Given this list of marker genes RIF1, RABGGTB, PAN3, TBXAS1, FAHD1, URB1, HCFC2, RMI1, NSD2, PHF3, RBM10, GCNT1, RREB1, H2BC21, TPRKB, FTSJ3, PPCDC, PDS5A, LRP6, OSBPL2, NARF, C2CD2, ATP10D, FUT4, PABPN1, TFEB, TLK1, TWNK, IMPACT, TMEM115, NCOR2, ARL11, KLF16, AKAP10, YTHDF2, MARVELD1, ACAP3, EIF2AK4, FAM50A, TRIM47, SLC37A4, TNRC6C, NT5DC3, ACOX3, CHUK, PHF2, ZNF486, HNRNPF, NUDT7, WWP1, AHCTF1, KIF13B, SLC66A1, SNAPC4, ARHGAP27, POLI, PDCD7, HDAC5, CERK, PDCD6, ABCD4, KLF10, SLC25A15, NBEAL2, METTL16, NOP56, MDP1, NAP1L4, WWC2, B3GALT6, RXRA, THUMPD2, BMAL1, PRKCH, MRPL49, METTL21A (NCBI Gene Id 151194), DGCR8, ADCY9, DEAF1, OPHN1, RIC8B, ACYP1, SESN1, PACC1, CNNM3, ZSCAN20, TUBGCP6, KIF13A, OXSM, PGP (NCBI Gene Id 79118), GNE, MIR340, MTRR, THAP12, TIA1, UQCC3, EHMT1, LIPT2, MEF2A, REPIN1, RDH13, TCF12, SLCO4A1, SP1, RAB3A, HGF, TBC1D12, LATS2, GRWD1, PREB, TANGO6, R3HDM1, FAM78A, HIRA, CTBP2, BBS4, RRP8, MBD6, NCKIPSD, CRAMP1, ZBTB1 (zinc finger and BTB domain containing 1), GPS2, CLPX, WDR81, FHOD1, B3GNT8, USP36 (NCBI Gene Id 80160), CD151, POLG, ORC5, INTS10, USP20, MINDY2, NUMB, TRAPPC10, PPID, ETV5, RRP1B, NSD1, STARD9, PNKP, SEC61A2, IPO7, TRMT12, PVT1, DDX50, MAP3K2, TMEM86A, ZNF638, PRUNE1, RBBP5, SIPA1 (NCBI Gene Id 6494), FNBP1, SFMBT1, DUS1L, LYL1, FAM76A, RBM15, PRKAG2 (protein kinase AMP-activated non-catalytic subunit gamma 2), HMG20A, MTIF2, SCAF8, here is a description of the gene set: The inflammatory response initiated by microbial products signaling through Toll-like receptors (TLRs) of the innate immune system is essential for host defense against infection. Because inflammation can be harmful to host tissues, the innate response is highly regulated. Negative regulation of TLR4, the receptor for bacterial lipopolysaccharide (LPS), results in LPS tolerance, defined as hyporesponsiveness to repeated stimulation with LPS. LPS tolerance is thought to protect the host from excessive inflammation by turning off TLR4 signal, which then shuts down TLR-induced genes. However, TLR signaling induces hundreds of genes with very different functions. We reasoned that genes with different functions should have different requirements for regulation. Specifically, genes encoding proinflammatory mediators should be transiently inactivated to limit tissue damage, while genes encoding antimicrobial effectors, which directly target pathogens, should remain inducible in tolerant cells to protect the host from infection. Using an in vitro system of LPS tolerance in macrophages, here we show that TLR-induced genes may indeed be divided into two distinct categories based on their functions and regulatory requirements. Further, we show these distinct groups are regulated by gene-specific, and not signal-specific mechanisms. Human Gene Set: GSE7348_UNSTIM_VS_TOLERIZED_AND_LPS_STIM_MACROPHAGE_UP from publication Foster SL, Hargreaves DC, Medzhitov R (PMID 17538624) Genes up-regulated in macrophages: naïve untreated versus tolerant stimulated by LPS. species: Homo sapiens